The following is a description of a gene set: A cohesin complex that mediates sister chromatid cohesion during meiosis; has a subunit composition distinct from that of the mitotic cohesin complex. Human Gene Set: GOCC_MEIOTIC_COHESIN_COMPLEX species: Homo sapiens, and this is the list of marker genes: RAD21 (NCBI Gene Id 5885), REC8, SMC1A, SMC1B, SMC3, RAD21L1, STAG3